Given this list of marker genes SOS1, FRS2, NRAS, HRAS, NTRK2, BDNF, GRB2, PTPN11, NTF4, KRAS (KRAS proto-oncogene, GTPase), FRS3, here is a description of the gene set: Reactome Pathway: Activated NTRK2 signals through FRS2 and FRS3 studied in species Homo sapiens Adapter proteins FRS2 and FRS3 can both bind to the cytoplasmic tail of activated NTRK2 (TRKB) receptor, which is followed by NTRK2-mediated phosphorylation of FRS2 and FRS3. NTRK2 signaling through FRS3 has been poorly characterized. Phosphorylated FRS2 is known to recruit GRB2 (presumably in complex with SOS1) and PTPN11 (SHP2) to activated NTRK2, leading to augmentation of RAS signaling. part of: Signaling by NTRK2 (TRKB)